The following is a description of a gene set: Catalysis of the reaction: a 17-beta-hydroxysteroid + NAD+ = a 17-oxosteroid + NADH + H+. Human Gene Set: GOMF_17_BETA_HYDROXYSTEROID_DEHYDROGENASE_NADPLUS_ACTIVITY species: Homo sapiens, and this is the list of marker genes: HSD17B8, HSD17B1, DHRS9, HSD17B4, AKR1C4, HSD17B2, HSD17B10, AKR1C3, HSD17B6